Given this list of marker genes TEX15, NR5A1, MEIOB, TDRD9, SYCP2, CATIP, here is a description of the gene set: Cryptozoospermia studied in species Homo sapiens Human Gene Set: HP_CRYPTOZOOSPERMIA A type of oligozoospermia in which spermatozoa can be detected in an ejaculate only after centrifugation and inspection of the pellet.